The following is a description of a gene set: Human Gene Set: GOBP_EMBRYONIC_VISCEROCRANIUM_MORPHOGENESIS The process in which the anatomical structures of the viscerocranium are generated and organized during the embryonic phase. The viscerocranium is the part of the skull comprising the facial bones. species: Homo sapiens, and this is the list of marker genes: LHX1, CHST11, NDST1, MTHFD1L, HOXA2, RDH10, NIPBL, TBX1, MTHFD1, FOXC2